Given this list of marker genes Mtpn, Atp2b2, Ophn1, Cbln1, Nfix, Kndc1, Nrxn1, Wnt7a, Ulk1, Prox1, Grid2, here is a description of the gene set: The process that gives rise to the cerebellar granule layer. This process pertains to the initial formation of a structure from unspecified parts. The granular layer is the innermost layer of the cerebellar cortex. This layer contains densely packed small neurons, mostly granule cells. Some Golgi cells are found at the outer border. Granule neurons send parallel fibers to the upper molecular layer, where they synapse with Purkinje cell dendrites. Mossy fibers from the pontine nuclei in the white matter synapse with granule cell axons, Golgi cell axons and unipolar brush interneuron axons at cerebellar glomeruli in the granule cell layer. Mouse Gene Set: GOBP_CEREBELLAR_GRANULAR_LAYER_FORMATION studied in species Mus musculus